Given this list of marker genes SMS, B4GALT7, PPP1R15B, TRMT10A, VPS13B, MTM1, here is a description of the gene set: Slender toe species: Homo sapiens Toes that are disproportionately narrow (reduced girth) for the hand/foot size or build of the individual. Human Gene Set: HP_SLENDER_TOE